Given this list of marker genes Vars1, Tars2, Iars1, Aars2, Lars1, Aarsd1, Lars2, Vars2, Dtd2, Dtd1, Iars2, Prorsd1, Aars1, here is a description of the gene set: The hydrolysis of an incorrectly aminoacylated tRNA. Mouse Gene Set: GOMF_AMINOACYL_TRNA_DEACYLASE_ACTIVITY studied in species Mus musculus